The following is a description of a gene set: KITLG-KIT-PI3K signaling pathway. Pathway ID: N00045. Pathway type: Reference. Pathway class: nt06275 Acute myeloid leukemia. Pathway Definition from KEGG: KITLG -> KIT -> PI3K -> PIP3 -> AKT -> MTOR -> S6K species: Homo sapiens Human Gene Set: KEGG_MEDICUS_REFERENCE_KITLG_KIT_PI3K_SIGNALING_PATHWAY, and this is the list of marker genes: RPS6KB1, MTOR, RPS6KB2, AKT2, PIK3CD, KITLG, KIT, PIK3CA, PIK3CB, AKT3, AKT1